Given this list of marker genes Grin2c, Dlg4 (NCBI Gene Id 13385), Grin2a, Dlg3, Calm1, Nefl, Grin1, Camk2b, Grin2b, Grin2d, here is a description of the gene set: part of: Activation of NMDA receptors and postsynaptic events Reactome Pathway: Unblocking of NMDA receptors, glutamate binding and activation This event has been computationally inferred from an event that has been demonstrated in another species.<p>The inference is based on the homology mapping from PANTHER. Briefly, reactions for which all involved PhysicalEntities (in input, output and catalyst) have a mapped orthologue/paralogue (for complexes at least 75% of components must have a mapping) are inferred to the other species. species: Mus musculus electronically inferred by orthology from the curated human pathway